Given this list of marker genes RYR2, PENK, PKLR, PDE4D, SIRT2, ADIPOQ, KCNQ1, SNCA, ATP2B4, SLC9A1, ABL1, RNLS, PDE4B, PRKACA, SRD5A1 (steroid 5 alpha-reductase 1), here is a description of the gene set: studied in species Homo sapiens Any process that results in a change in state or activity of a cell or an organism (in terms of movement, secretion, enzyme production, gene expression, etc.) as a result of an epinephrine stimulus. Epinephrine is a catecholamine that has the formula C9H13NO3; it is secreted by the adrenal medulla to act as a hormone, and released by certain neurons to act as a neurotransmitter active in the central nervous system. Human Gene Set: GOBP_RESPONSE_TO_EPINEPHRINE